Given this list of marker genes SLC18A2, EDN1, VAMP7, LYN, PLA2G3, SNAP23, SNX4, VAMP8, SNX6, VAMP2, BTK, VAMP3, RAB44, CSF2, here is a description of the gene set: The regulated release of histamine by a cell or tissue. It is formed by decarboxylation of histidine and it acts through receptors in smooth muscle and in secretory systems. species: Homo sapiens Human Gene Set: GOBP_HISTAMINE_SECRETION